The following is a description of a gene set: Genes containing one or more binding sites for (ZIM3) in their promoter regions (TSS -1000,+100 bp) as identified by GTRD version 20.06 ChIP-seq harmonization. from publication Yevshin I, Sharipov R, Kolmykov S, Kondrakhin Y, Kolpakov F (PMID 30445619) Human Gene Set: ZIM3_TARGET_GENES studied in species Homo sapiens, and this is the list of marker genes: GAPLINC, MIR1273C, ARHGEF7, ITM2C (NCBI Gene Id 9523), LINC03046, SEC23IP, INTU (NCBI Gene Id 27152), SMARCD3, SAT1, ARNT, ZNF19, ACAD8, VPS8, IK (IK cytokine), KCTD21-AS1, CD69, MORN5, ADD3, SYNJ2, OGDHL, ABCB7, SLC39A14, CYP1B1-AS1, MIR584, CSNK1E, SHC3, ANXA3, RNA5SP40, MAGI1, FAM76B, LRRK1, LINC01581, DZIP1L, LINC01944, DSTYK, UBAP2, LINC03048, GLUL, BUB1, NIBAN1, USP30, RNF115, LRIF1, MYB, METRNL, PDE1A, DROSHA, SH3TC2-DT, LINC01182, ANAPC10, SMARCE1P3, CLPSL1, ADGRF4, ATRX, NIN, DIXDC1, WDR24, SDHAF3, ING3, PNKD, YKT6, NUDT19P5, SYNE1-AS1, PHETA1, WDR81, CD59, PPM1M, EYA1, LINC00887, METTL16, H4C5, KRTAP10-5, PHLDA1-AS1, TAX1BP1, SYPL2, UBE2E1-AS1, PLEKHM1, LINC02526, NUP155, MIR1302-4, ICA1, RNU5F-8P, H4C8, ELL2, EPB41L3, RNU7-80P, NICN1, YIPF6, MAST1 (NCBI Gene Id 22983), SON, NFE2L3, JAM3 (junctional adhesion molecule 3), MPPE1, TARBP1, ARHGEF10L, RBM22, TBC1D15, SH3D21, LCE3D, SLC38A2, CD84P1, CIC, RNVU1-21, ATP6V0A1, DOCK2, ZCCHC7, MOCS2, LIMS2 (LIM zinc finger domain containing 2), TMEM26, LINC02779, OTUD7B, LIMS1, FIS1, GUCY2EP, LINC03000, PCTP (NCBI Gene Id 94001), C17orf75, MIR425, MAP3K7CL, ENSG00000264985, LRRK2-DT, SCIN, MORF4L1P7, MIR191, KDM5B, SETD5, LINC03098, ZNF454-DT, FYB1, PFKM, OAF, WWP2, H2AC25, KHDC4, PYCR1-AS1, FGF13, GCNT2, PSMD11, MAGI2-AS3, SIRPG, STRA6, STAT3, HLA-DQB1-AS1, ZNF233, KRBOX4, MYOT, C1QTNF3 (C1q and TNF related 3), IQCH, TMEM123, HIBCH, PPP1CC, TMPRSS3, CACNA1C, ZNF461, REN, MIR4716, MIR3691, COX6CP6, ABCA3P1, LETM2, GNB1, LDHAP1, PGAP4, RN7SL823P, CCDC144BP, IL17D, ZMYM1, RXFP2, C6orf89, SNCAIP, MYNN, CDK3, NT5C, ADGRL2, ARID3B (AT-rich interaction domain 3B), LRRC8A, EIF5B, FUBP1, TEX41, RN7SL442P (RNA, 7SL, cytoplasmic 442, pseudogene), MACF1, RANGAP1 (Ran GTPase activating protein 1), DEPDC4, CEP57, ROR2, CASC3, ARMC2, TAB2 (NCBI Gene Id 23118), CLMP, PLAU, SEC16B, TRIM38, COA1, WEE1P2, KCNA1 (potassium voltage-gated channel subfamily A member 1), INPP5A, DNAJB12, CCDC28B, RNY4P27, ANAPC15, TRAJ44, TRAJ17, LINC03065, RN7SL268P, CLCN3, LINC02540, VPS51, SYTL2, INTS14, LINC01603, FAXC, ST20, RNPC3-DT, PJA2, CMYA5, ACADS, NID2, PHF13, REPS1, RNU5F-3P, MGST3, PCNX2, LAPTM4A, FGD6, XXYLT1, CLTCL1, FAM228B (family with sequence similarity 228 member B), RMDN1, DLX1 (NCBI Gene Id 1745), JADE1, EMC3-AS1, GAS2L3, MIR5087, RCAN2, GPBP1L1 (NCBI Gene Id 60313), SNORA50C, RNGTT, TM9SF2, COX7A1, SH3GLB1, LINC03047, SYBU, ZNF573, PRKACB, RPL3P9, MPZ, AK9, DAPK3, ADD1, MLX, CSNK1A1, RNF20, LINC01101, MRPS14, ANXA2, NUSAP1, NOP2, MED23, MSH2, RBM33, TRAF3IP2, LINC01485, FAM230G, NEDD8, RAD54L2, RPE65, PHF21A, MAPT (microtubule associated protein tau), RPS29P7, UTP3, AGBL1, ART3, PAPOLG, CYP27C1, TSFM, GLB1L3, DNM1L, DIS3L, FRY, MIR525, ARHGEF2, UPB1, CRYBG2, RFX4, FAT3 (NCBI Gene Id 440062), DDX24, LINC02073, PGD, PPM1K, TIMM29, CC2D2B, PRR3, HCG21, KIAA1217, LYRM4, RASL11B, CEP72-DT, RBM11, RGS5, SIRT2 (NCBI Gene Id 22933), SF3B2, FTH1P25, RNF4, ATOH1, C18orf54, ENSG00000251922, ADGRE3, RPL29P15, H2BC15, SOX9-AS1, COPS7B, NUFIP1, RNU6-1062P, EIF4ENIF1 (eukaryotic translation initiation factor 4E nuclear import factor 1), PPP2R2A, EPC1, NCOA7, HMGB1, HIVEP1, WRNIP1, ZNF337-AS1, MAD1L1, ACOXL-AS1, OSTF1P1, C1orf159, RNU6-639P, INSIG2, TENT4B, MCFD2, CREBRF, SLC7A14, ZNF821, ALG8 (ALG8 alpha-1,3-glucosyltransferase), MMAA, TENT5B, DHRS2, RNU6-36P, TBCD, MCCC2, SNORA23, GPR179, EXOC1, YARS1, MIR450A1, CD24, BCL3, S100A2, PTTG1IP, ALDH1B1, MIR591, SH3BP5L, DLG3, DTL, SMNDC1, STXBP5L, LLPHP3, TBC1D28, SLC16A1, SUPT5H, AKAP9, ATXN1, CCDC70, LINC00910, ZNF330, GALNT13-AS1, GPALPP1, ATXN3L, RPL17P37, SWT1, DAD1, RPL17P12, RD3, SELL, MRPS31, LINC02541, SEMA6D, HYKK, SCAND1, CSK, GNL1, CLPTM1L, PRR13P3 (proline rich 13 pseudogene 3), TYSND1, TEN1-CDK3, MIR6823, ZNF232, GABPB2, CD300C, UBR5, THAP10, MLLT3, ENSG00000266401, RNF43, LINC01572, SLC49A3, RHOT1, CACNG2, DNM1P35, KLHL10, FA2H, ELF2P3, EMSY, NUDT13, ACACA, NRG4, NOS2 (NCBI Gene Id 4843), ZPLD2P, DNM3OS, ZNF189, TRMT1L, SPEF2, KDR, DISC1, CYCSP4, RRAGA, RBM47, RPL7P34, GNPNAT1, OAS1, LINC01364, VBP1, CTTNBP2 (NCBI Gene Id 85447), TBCCD1, AP2A2, SMAD4, SOX6, PFKFB4, SRRM2, HEPACAM, PLCL2, U2AF1L4, BMPR1B, DDX19B, NDUFAF3, WFDC21P, HDAC7, RAET1K, VCPKMT, DENND4A, ZBTB17, LINC03103, SLC16A4, LTBP4, SCGB1D2, SPAG9 (sperm associated antigen 9), SH3GL1, TUG1, POLR3E, CFAP61, PKP4, NKAIN2, SNRNP40P1, ANK3, ABHD16A, ZNF10, SCAF11, PGAM1P5, SLC15A1, SNHG25, ARHGEF12, TLE1-DT, RNPC3, OFCC1, SSBP1, ZNF454, STMND1, ATM, WNK1, G3BP2, DBP, PAPOLA, KLRK1, CCDC28A-AS1, LINC02740, PCM1, RBM41, PRKCH, UGT1A2P, ANKRD6, SLC22A2, FAM227A, PATJ, GPX8, RBBP7, IFT80, MIR523, CDC42BPA, CCDC80, EXOSC10, S1PR3, TMEM116, TMCC1, TMEM218 (NCBI Gene Id 219854), SLC5A1, SENP7, GPR82 (NCBI Gene Id 27197), CDC42SE1, ZNF146, MAML1, UBXN8, NCOR1, DRG2, KIAA0753, S100A13, TADA1, RCOR1, SEC14L1P1, RBM43, DNAJC5G, PTGIR, TMEM242, COQ8B, MAPRE3, E2F2, KCTD5, FANCD2P2, TRAF3IP2-AS1, ADPGK-AS1, KMT2C, PSEN2, LRRC63, EMC3, ITGAL, TOP6BL, LINC02268, HAVCR1, HSPA4L, MKNK1-AS1, MRTFB, MRPL22, TBC1D3P7, ALG9, EHMT1, SFN, ANP32E, RNASE4, ENSG00000252274, CKMT2-AS1, PREX1, MAN2C1, C12orf76, HNRNPUL1, SNORA62, IGF1R, DSG1-AS1, MTCO3P12, IFT70A, ENSG00000260209, SCN2A, PPIAP51, MLIP, RNA5SP158, ZNRF3-AS1, SPECC1P2, ATP5MFP4, RXFP4, ZNF536, RPL4, TYRO3P, TNFAIP8L2, CEP83 (NCBI Gene Id 51134), HYAL4, ZFAND6, PAQR3, MIR8086, COL6A3, SNORA11B, CCL27, SNORD121B, ANKRD55, PIAS2, NUDT16-DT, BLVRA, SIPA1L1-AS1, MAST2, ANAPC7 (NCBI Gene Id 51434), IPO5 (NCBI Gene Id 3843), PLS3, ENSG00000241525, AP3B1 (NCBI Gene Id 8546), RAPGEF4-AS1, WLS, SELENOP, WDSUB1, BCAS2P2, RNU5E-4P, PIP4K2B, OR1AB1P, NUF2, SRRM3, TRAPPC2, MIR217HG, H2BC26, ASAP1, PLCH1, MIR450B, CDKL3, ESR1, PPARG (peroxisome proliferator activated receptor gamma), ENSG00000237813, ASCC3, TRAJ43, SNORD38A (NCBI Gene Id 94162), TXLNB, PLD3, UFC1P1, GARNL3, GLT8D2, RNU4-5P, WDR20, ST3GAL1, GATAD2A (GATA zinc finger domain containing 2A), ZNF365, KLHL22, SOX13, RNVU1-14, ALDH1L1 (aldehyde dehydrogenase 1 family member L1), SMPD2 (sphingomyelin phosphodiesterase 2), CLIP1, ACOD1, SEPHS2, UST-AS2, PTK7, TMEM196, POLG2, LINC02873, DLGAP1-AS2, LATS1, MIR4438, PPL, IGLV3-24, PRKAR1B, HELQ, AGPS, NCAM1, LIPE-AS1, GAPDHP73, CD4, DENND2B, RPS8, COL6A5, STARD6 (NCBI Gene Id 155089), LINC01345, PDGFRL, GARS1-DT, RGS12, SPART-AS1, USO1, MED12L, SEC22B, ENSG00000234255, ENSG00000254839, MTND5P11, SGK1, FAM3A, STARD7, RNU7-74P (RNA, U7 small nuclear 74 pseudogene), ZNF227, CFAP65, SNRPGP10, ZNF621, ZNF584-DT, TXNRD1, WDR49, LINC02768 (long intergenic non-protein coding RNA 2768), KANSL1, TANK-AS1, HSF1 (heat shock transcription factor 1), ATP5F1EP2, CEMIP, CTPS2, KPNA3, PDS5B, DNAAF1, UBE2B, PDCL2P2, ZAN, PLA2G6, CSRP2, DERL2, RPL17P50, MYO15B, PANK2, RN7SL674P, FMO9P, CYRIA (CYFIP related Rac1 interactor A), TMEM97P1, CDKN2B, CREBBP, LINC00928, TVP23B, LIG1, KCTD9P5, TAGLN2, DAP-DT, RBM17, PPIAP82, LINC03066, MB, MIR548H5, NT5C3B, ENSG00000247416, SEC14L1, RRM2P3, ACAP3, CALCRL (calcitonin receptor like receptor), NFU1, TRPM7, ABCC3, CCDC28A, TNPO1, RPL37, RNA5SP512, CNOT2, TNFRSF13B, GAR1, NR1H2, FAM186B, LINCMD1, BTBD10, AFDN, ABI1, SMO, TTC8, SAXO1, LINC00596, MXRA7, PAX8-AS1, RABEP2, RNU7-61P, MAPK10, SYCP1, TMEM69, HMCN1, ZCCHC14, MIS12, LINC02100, FNDC3A, IQCJ, WNT7A, KLC1, LINC00242, KIF1B, CCDC87, RNU6ATAC24P, ASIC4-AS1, MAP1S, KIF7, SNORD118, LRIG1, CHD2, DYM, ENSG00000212581, CDK11B, GCNT1P3, DKC1, CFAP45, COL21A1, COPS4, SPART, SMC4 (structural maintenance of chromosomes 4), ANKS3, SNORD104, POLR3H, MBTPS1-DT, RNU6-454P, NT5C2, OLFM1, DYNC1LI2, RPL12, SRGAP3, ZFR, IDE, ATG4C, OXR1, ZNF674, RABGAP1L, ZNF25-DT, CDC25A, TMEM202-AS1, RNU6-490P, TYW5, RAD23A, SNRPEP9, DDR1, C5orf22, OSBPL8 (NCBI Gene Id 57601), SGK3, GPR22, DHRS7, CDK11A (NCBI Gene Id 986), CNDP1, ITGB1, EFCAB6-DT, ENSG00000248964, CACYBPP1, TMEM201, TOM1L2, TJP3, TTC23, SPPL3, MIR4510, ZNF382, COQ8A, ZBTB38, ETV1, TCL6, NFIA, IAH1, STYK1, RSPH4A, MAP3K9 (mitogen-activated protein kinase kinase kinase 9), COX15, ODAD4, DUSP6, ESCO2, GSTP1, LNCATV, GOSR1, HAUS3, KLF7, FNBP1P1, PHC3, FAM83A-AS1, SMARCD2, SAAL1, PSMA4, RN7SL336P, POGLUT3, SP2, IL6ST, LRSAM1, PHF10, YTHDF2, FRMD3, LEF1-AS1, PPM1A, NWD1, ENPP3, INTS12, AGAP3, EPN3, PJA1, COMMD10, MIR450A2, VN2R3P, SHOC1, VWA8, ZCCHC2, GRHPR, BBX, HDAC6, GPRC5B, HLA-V, NT5C3A, MTRFR, SPMIP3 (sperm microtubule inner protein 3), MIR6086, TTC28, LINC02448 (NCBI Gene Id 105369792), SIMC1, TMEM242-DT, RNU6-236P, MARK3, CDK5RAP1, ERLIN1, PPM1K-DT, BLTP1, TSHZ2, PAICSP3, MAST4, MGAT4D, SAYSD1, PHKA2-AS1, PHIP (NCBI Gene Id 83843), ANG, CCDC144NL-AS1, THRB-AS1, GSTCD, ZNF236, LIMS1-AS1, IL31RA, CEP192P1, VWA8-AS1, MAP3K9-DT, POLR3C, FAM204A, NEDD8-MDP1, ILRUN-AS1, RNA5SP356, RPS12P23, POLN, LINC01206, NKAP, SARAF, ST7L, ACLY, R3HDM2, GRM8, NKAIN1, CATSPERG, URM1, STK17A, C8orf34, NDUFA2, BCL6 (NCBI Gene Id 604), S100A14, CEP162, PPIL6, CMC2 (C-X9-C motif containing 2), MAEA, PPP1R13B, SNF8, RNF146, SNTB1, SCLT1, MREG, FOXP1, COQ5 (coenzyme Q5, methyltransferase), ZWINT, MTHFD2P3, RN7SL845P, RNU6-1035P, FDXR, ST3GAL1-DT, CHEK2, KRT32, PNPLA3, CCS, UBE2E3, RNU6-999P, ZNF25, TIMM44, ZNF43, VPS26BP1, RNU6-215P (RNA, U6 small nuclear 215, pseudogene), LTBP1, HNRNPC, WDR1, MAMDC2-AS1, MRPL39 (mitochondrial ribosomal protein L39), PPIAP55, NOL4L, SNORA75, ATF4, HEXA-AS1, ADIPOR1P1, DMAP1, ENSG00000232995, GBA1, WDR25, SEMA4A, WDTC1-DT, ELP3, MRPL50, SERINC3, IZUMO2, TACO1, BRF2, SCNN1A, ALG13, CNTFR-AS1, EFCAB5, YIPF2, TRPC6P5, SEPTIN9, LSM6, TAS2R30, NRAS, SLC35A5, MTMR1, MTDHP4, ERVE-1, PDIA5, SVOP, ARL8B, CCT6A, YES1, FBXO36P1, BMS1P19, GABRA3, CABLES2, CDC37L1, ID3, FOXP1-DT, TRIM34, PRRT1B, CNOT6L, IPO4, CARD8, HMGB1P28, SPECC1, ETFBKMT, NHSL2, ME2, ENSG00000260378, S100A10, EVA1C, SH3BP5, PSMD3, CCDC91, MRPS31P5, PRR13P2, TAC3, RPL29P19, STK33, RPL7L1, REV1, CDC73, LNCTSI, FGGY, TLR4, NADK2, THSD1, KIAA2012-AS1, GAR1-DT, CUTC, GDI2, COX7BP6, TTC19, MECP2, GALK2, SCAPER, BABAM1, LIG3, HNRNPA1P31, ENTPD7, EIF4G3 (eukaryotic translation initiation factor 4 gamma 3), ZNF875, ABCE1, ZNF568, RLBP1, SLC38A4-AS1, RCC1, RAPGEF6, GARS1, CTBP2P6, IQCJ-SCHIP1, TH2LCRR, ENSG00000253163, RN7SKP141, XKR3, ZFYVE27, ATF7IP, RPL29P25, EMSY-DT, SLC24A1, DDX50, SGCA, DUS1L, ENY2, CAPZB, DOP1B, PTPN12, LRCH3, HADH, GINS1, PARP6, TRAJ11, ENSG00000278899, TM7SF2, SNX13, ATXN3, SLC22A4, WNT2B, MIR6722, VEZT, SLFN13, RNU6-147P, RN7SL30P, HIC1, GMPR2, LYRM9, BMS1, RNU6-344P, ANO4, FAM168A, MTRR (NCBI Gene Id 4552), SMARCA5-AS1, CAPN2, BACH2, SELENOTP2, RUFY2, ZNF566, QRICH1 (NCBI Gene Id 54870), RNU2-4P, RPL21P66, AQP4, IGFLR1, NFIL3, GAS5, EBLN3P, THUMPD3-AS1, UBE4B, SPRYD4, SLC4A1AP, SYT16, USP11, GAS7, EFCAB6, RPL35P8, SYNE2, RPSAP64, TATDN1, FBXO16, TMOD3, DYNC1I2, PGGHG, ARMCX5, MRPS22, IST1, LINC00649, CSF1R, LRRK2, CIITA, NCOA4P4, CA14, SUCLA2, UBA5, BMP6, METTL25B, DDX52, ARHGAP9, PA2G4P4, TDRD9, SPRED2, SLC50A1, USPL1, PCID2, REG4, CYRIB, LINC-PINT, LYSMD4, LINC02583, LINC01619, LYAR, MRPL37, CCDC192, FAM47B, DUSP5-DT, CFLAR, SCNM1, KCTD1, NAV2-AS3, ACACB, LIAT1, ARHGAP32, TCP10L2, RPS17, WDR13, CRYL1, PIK3IP1-DT, ARHGEF28, PLEKHG5, LINC01548, ID4, ALDH7A1, HPS1, RPL7AP54, RPL38, CSGALNACT1, ACADVL, RASGRF2, JPX, MDM1, KCNN4, ODF4, RLN1 (relaxin 1), WEE2-AS1, HCFC2 (host cell factor C2), KIAA1586, MTMR12, ATP13A4, UBE2E1, FBN2, RHOC, IPO11, CEPT1, CA5B, CLOCK, PKD2, PECR, PLCXD2, MTRF1, ZNF232-AS1, CSDE1, PMM2, MIR335, RN7SL604P, MFAP3